The following is a description of a gene set: Mouse Gene Set: CUI_MAST_CELL_41BBL_RESPONSE_UP from publication Cui A, Huang T, Li S, Ma A, Pérez JL, Sander C, Keskin DB, Wu CJ, Fraenkel E, Hacohen N (PMID 38057668) Genes positively differentially expressed in cell type: Mast cell upon treatment with cytokine: 4-1BBL in mouse lymph nodes in vivo. studied in species Mus musculus Cytokines mediate cell-cell communication in the immune system and represent important therapeutic targets. A myriad of studies have highlighted their central role in immune function, yet we lack a global view of the cellular responses of each immune cell type to each cytokine. To address this gap, the authors created the Immune Dictionary, a compendium of single-cell transcriptomic profiles of more than 17 immune cell types in response to each of 86 cytokines (>1,400 cytokine-cell type combinations) in mouse lymph nodes in vivo. A cytokine-centric view of the dictionary revealed that most cytokines induce highly cell-type-specific responses. For example, the inflammatory cytokine interleukin-1β induces distinct gene programmes in almost every cell type. A cell-type-centric view of the dictionary identified more than 66 cytokine-driven cellular polarization states across immune cell types, including previously uncharacterized states such as an interleukin-18-induced polyfunctional natural killer cell state., and this is the list of marker genes: Dnmbp, Timm22, Pet100, Zfp710, Zfp472, Clasrp, Cdpf1, Zfp931, Htra1, Gabbr1